Given this list of marker genes Nanog, Eomes, Sox2, Dkk1 (NCBI Gene Id 13380), Hnf1b, Pou5f1, Sox17, Mesp1, here is a description of the gene set: Mouse Gene Set: GOBP_ENDODERMAL_CELL_FATE_SPECIFICATION studied in species Mus musculus The cell fate determination process that results in a cell becoming capable of differentiating autonomously into an endoderm cell in an environment that is neutral with respect to the developmental pathway; upon specification, the cell fate can be reversed.